Given this list of marker genes Plod3, Pxdn (peroxidasin), Phldb2, Lamb2, Ntn4, Lamb3, Lamb1, Phldb1, Megf9 (NCBI Gene Id 71014), Dag1, Ramp2, Clasp1, Clasp2, here is a description of the gene set: studied in species Mus musculus Mouse Gene Set: GOBP_BASEMENT_MEMBRANE_ASSEMBLY The aggregation, arrangement and bonding together of a set of components to form a basement membrane, a part of the extracellular region that consists of a thin layer of dense material found in various animal tissues interposed between the cells and the adjacent connective tissue.